The following is a description of a gene set: Human Gene Set: HP_ABNORMAL_LARGE_INTESTINE_PHYSIOLOGY Abnormal large intestine physiology studied in species Homo sapiens A functional anomaly of the large intestine., and this is the list of marker genes: SI, EXT2, TP63, NOP56, RREB1, ATP13A2, FMR1, SLC44A1, EIF2AK2, ZEB2 (zinc finger E-box binding homeobox 2), HPS6, GPR35 (NCBI Gene Id 2859), VANGL1, ISL1, LRIG2, ARSA, UFD1, ATRX, GABBR1, ARVCF, TBCD, KY, PSAP, JMJD1C, MAPK1, ABCD1, GP1BB, FUZ, PLP1, HTRA1, COMT, DSTYK, DMPK (NCBI Gene Id 60405), DACT1, DDHD2, MST1, ZFYVE26, CFAP43, FA2H, CRKL, VCP, BCR, TCF4, UBAP1, GLA, SEC24C, SCN4A, RTN2, FLVCR1 (FLVCR choline and heme transporter 1), SLC9A6, HPSE2, FGFR3, SEMA4D, TBX1, SALL1, MAPK8IP3, HIRA